The following is a description of a gene set: Binding to an interleukin-1 receptor. Human Gene Set: GOMF_INTERLEUKIN_1_RECEPTOR_BINDING studied in species Homo sapiens, and this is the list of marker genes: TLR9, IL36G, ERAP1, MYD88, IL36A, IL1A, IL37, TLR5, IL1F10, TRIP6, IL1RN, IRAK4, IL36RN, IL1B (NCBI Gene Id 3553), TOLLIP, IL36B (NCBI Gene Id 27177)